The following is a description of a gene set: Genes predicted to be targets of miRBase v22 microRNA mmu_miR_6915_3p in miRDB v6.0 with MirTarget v4 prediction scores > 80 (high confidence targets). from publication Chen Y, Wang X (PMID 31504780) species: Mus musculus Mouse Gene Set: MIR_6915_3P, and this is the list of marker genes: Nucks1 (nuclear casein kinase and cyclin-dependent kinase substrate 1), Zfp663, Zic3, Ankrd12, Pter, Cep68, Cpeb4 (cytoplasmic polyadenylation element binding protein 4), Trpm3, Cks1b, Trmt2b, Trim44, Sema3c, Nlk, Prpf4, Kxd1, Dhx32, Abhd10, Myt1, Mtss1, Cd200r1, Rasal2, Flrt3, Glul, Tpm4, Zfp386, Ddx5, Pik3r3, Tnrc6b, Rnf114, Dclk1, Parg, Dnaja4, Hells, Arhgap42, Olfm5, Hmgcr, Fktn, Tmem54, Atp11a, Ubr5, Me3, Gzmb, Plppr1, Cabyr, 1600014C10Rik, Zfp341, Hs6st2, Atp6v1b2, Fyttd1, Hapstr1, Atxn2, Cttnbp2, Serpinb9, Gm10220, Cxcl9, Mgat2, Mycn, Ctnnb1, Ddx19a, Zfp24, Tmem178b, Mier3, Lrrcc1, Tsnax, Ppp1cc, Otx2